The following is a description of a gene set: Genes predicted to be targets of miRBase v22 microRNA mmu_miR_3062_5p in miRDB v6.0 with MirTarget v4 prediction scores > 80 (high confidence targets). Mouse Gene Set: MIR_3062_5P from publication Chen Y, Wang X (PMID 31504780) studied in species Mus musculus, and this is the list of marker genes: Ugt2b1, Ccdc89, Lrrn4cl, Lpar1, Dlg3, Pde6d, Gpr158, Ptpn4, Nek9, Slc23a2, Npas3, Camk4, Tmem245, Twist1, Snx6, Gucd1, Arfrp1, Pclo, Pcdh10, Dgke, Gpc6, Clasp2, Kbtbd7 (NCBI Gene Id 74773), Ubr3, Kcnb2, Cers6, Slc8a1, Vps37c, Ralgapa2, Steap2, Xlr5a, Trio (NCBI Gene Id 77730), Ap3m1, Cpne8, Fkbp15, Camsap2, Zbtb34, Lmx1a, Psg25, Caps2, Acp3, Arih1, Ilf2, Zswim6, Vps54, Dlg5, St6gal2, Tbc1d10b, Ptk2, Shox2, Cdkn2c (cyclin dependent kinase inhibitor 2C), Rnf2, Pgm2l1, Cog6, Dclre1b, Clic6, Marchf7 (NCBI Gene Id 57438), Fbxo4, Cttnbp2nl, Sh3pxd2a, Ap1g1, Dnajc12, Ngly1, Fbxw11 (F-box and WD-40 domain protein 11), Vmn1r56, Ano3, Sumo2, Dusp16, Nsun6, Slc6a1, H3f3a, Glis3, Tenm4, Siah1a, Crot, Adamts6, Med26, Kdm5a, Vps4b, Kcns3, Sec63, Heph, Cep41, Lrrc39, 9930012K11Rik, Clock